The following is a description of a gene set: Human Gene Set: HP_SPARSE_EYEBROW studied in species Homo sapiens Sparse eyebrow Decreased density/number of eyebrow hairs., and this is the list of marker genes: EDARADD, ATR, ANTXR1, RECQL4, RNU4ATAC, THUMPD1, LPAR6, KRT74, DLX4, NSUN2, KAT5 (lysine acetyltransferase 5), KANK2, KAT6A, LRP1, KDF1 (NCBI Gene Id 126695), LARP7, DPH1, CDH3, SPRED2, TMEM147, WDR26, LMNA, SOS1, MARS1, NECTIN1, ST14, ALX4, JARID2, KIFBP, ALX1, BANF1, NFIB, KMT2D, LZTR1, NAA10, KDM1A, KDM6A, USB1, SMS, POGZ, DPH2, RNF113A, SOS2, HNRNPK, YY1, KRAS, NUP188, RAP1B, CEP120, ZMPSTE24, CDC42, LMBRD2, PURA, FAM111B, PLXNA1, KRT25, HRURF, RHOBTB2, STAG2, SPINK5, SPOP, KRT71, MEIS2, PIGK, EDA, MAB21L1 (NCBI Gene Id 4081), WLS, DSG4, SNRPE, VAC14, COL11A1, DSP (NCBI Gene Id 202512), TRPS1, GJB6, RIN2 (NCBI Gene Id 54453), MAPKAPK5, RAF1, B4GALT7, ATAD3A, KRT17 (NCBI Gene Id 5103), PQBP1, CLDN1, ITGA3, CWC27, IRX5, CDC42BPB, MED12, MBTPS2, TBCD, DNA2, CRIPT, HDAC4, FBXO11, CNTNAP2, TP63, LTV1, GJB2, LSS, TWIST2 (twist family bHLH transcription factor 2), DSC3, BRF1, APCDD1, TCF4, AARS1, WDR35, PUM1, H3-3A, PPP2R3C, NSD1, SON, H4C5, CTCF, FIG4 (FIG4 phosphoinositide 5-phosphatase), HERC1, RPL21, EDAR, PPP1CB, CHST3, DOLK, BRD4, UBE3B, MAN1B1, GAD1, GNPTAB, SIAH1 (NCBI Gene Id 6477), ODC1, DPH5, LIG4, DDX3X, MEGF8, MED12L, RPS28, HECW2 (HECT, C2 and WW domain containing E3 ubiquitin protein ligase 2), EBP, SMARCA2, PIGL, KMT5B, RNU12, JUP, WNT10A, TBX3, COG6, MTX2, RMRP, WNT10B, MESD, NF1, GJA1, CHD6, LIPH, GTPBP2 (GTP binding protein 2), HEPHL1, POLR3A, MED25